Given this list of marker genes Bach2, Ppm1b, AI987944, Msantd2 (Myb/SANT-like DNA-binding domain containing 2), Tmem200a, Rab40c, Zfp449, Rora (NCBI Gene Id 319897), Ankrd28, Afap1l1, Cnga4, Glo1, Gtf3c3, Neurod1, Thbs2, Mageb4, Kif15, Fez2, Bcor, Cplx4, Gabrb2, Fmr1, Mkrn1, Pfkfb2, Robo2 (roundabout guidance receptor 2), Vps35, Nek4, Hsd3b7, F11, Atad1, Spdye4a, Gabrg2, Dclre1c, Slc30a5, Cap2, Kcnj3, Ap1s2, P2ry10b, Mob4, Cacnb4, Tnfrsf9, Cdkn1b, Lats2, Pxk, Nop58, Snrnp27, Elmo3, Apol9b, Rbfox1, Epgn, Bclaf1, Cdca8, Diras2, Mbd5, Abca9, Ppp2r1b, Ppp2cb, Sp1, Col15a1, Pdzd2, Atad3a, Slc35e2, Igfbp7, here is a description of the gene set: Genes predicted to be targets of miRBase v22 microRNA mmu_miR_466b_5p, mmu_miR_466o_5p in miRDB v6.0 with MirTarget v4 prediction scores > 80 (high confidence targets). Mouse Gene Set: MIR_466B_5P_MIR_466O_5P studied in species Mus musculus from publication Chen Y, Wang X (PMID 31504780)